Given this list of marker genes Dcp1a, Dcp2, here is a description of the gene set: Reactome Pathway: Butyrate Response Factor 1 (BRF1) binds and destabilizes mRNA This event has been computationally inferred from an event that has been demonstrated in another species.<p>The inference is based on the homology mapping from PANTHER. Briefly, reactions for which all involved PhysicalEntities (in input, output and catalyst) have a mapped orthologue/paralogue (for complexes at least 75% of components must have a mapping) are inferred to the other species. studied in species Mus musculus electronically inferred by orthology from the curated human pathway part of: Regulation of mRNA stability by proteins that bind AU-rich elements